Given this list of marker genes TUBA3E (NCBI Gene Id 150521), H2AZ1, SLC25A11 (solute carrier family 25 member 11), DDB2, CCNT2, STAG1, PCSK1, DLL4, PDGFRA, EGLN2, NIPBL, FHIP1B, MARCKSL1, DPYSL2, RIBC1, RAB11B, LUC7L2, STT3B, ARF3, ZIM2, RAD51, MAT2A, AUTS2, OSBPL7, H2AC12, CDKN1A, NUTF2, ATE1, DCK, LIG1, FMO4, SALL1, ANKHD1, JADE2, NRIP3, CTCF, MCM4, FBXL20, CTDSPL2, ATP6V1D, DMD, ASXL2, DCTPP1, ODAD3, YTHDC1 (YTH N6-methyladenosine RNA binding protein C1), SRSF1, REPS2, RET, SUGP1, ID3, DNAJC9, ZNF687, TCP1, PCYT2, NSD3, CSRNP1, CPSF7, TIPIN, PRKCSH, MRPL18, PLAGL1, AGFG2, RMI2, ING3, PTMA (prothymosin alpha), TMEM131L, DNAJC11, TOPBP1, CDC25A, DNMT1, TRIR, PAN2, MXD3, PDS5B, SMC1A, E2F7, MCMBP, CBX5, USP49, GPAT2, NR3C2, PUF60, ZBTB8OS, H2BC10, HNRNPD, FANCG, TMEM187, SEMA5A, POLA1, PLD5, SLC16A2, PPM1D, UXT, RBBP4, PPRC1, PRRT2, RHD (Rh blood group D antigen), KCNA6, DMC1 (DNA meiotic recombinase 1), JPH1, ORC1, SEZ6 (NCBI Gene Id 94007), RPL28, AP4M1, DIO3, HMGN2, NR6A1, E2F3, CDC45, LGALS1, DCLRE1A, POLA2, GRIA4, RNF121, PPP1R9B, TIAM1, ANP32A (acidic nuclear phosphoprotein 32 family member A), EIF4G2, CDCA7, RNF167, TRMT2A, ZSWIM9, LRRC56, PDS5A, DLST, YPEL5, ZIC3, ARHGAP6, ZDHHC17, EIF5A, KLHDC3 (NCBI Gene Id 116138), SRSF2, MCM2, ATAD2, ZNF565, EZH2, BTBD10 (BTB domain containing 10), NUP153 (NCBI Gene Id 9972), ZGRF1, GAPDH, PODN, EIF2S1, SERBP1, NHLRC2, TLE3, H1-3, SASS6, SLBP, NRGN, GLRA3, ZNF367, ZMYM2, KNTC1, PKMYT1, SIK2 (salt inducible kinase 2), PEG3, RSRC2, CTDSP1, FBXO5, FAM219A, RCOR2, KCTD15, DAXX, PPM1J, ARHGAP36, KLF5, CNBP, NR4A2, E2F1, NECTIN1, RANBP1, BRMS1L, MECOM, JADE1, EPHB1, RPS20, FAM120C, SUV39H1 (SUV39H1 histone lysine methyltransferase), STAG2, GABPB2, ARHGEF17, CASP8AP2, UFD1 (NCBI Gene Id 7353), MAZ, OVOL2, TOP1, KMT5A, KCND2, IER5L, ADAMTS2, ZNF362, EVA1B, PRPS1, NABP2, PRKDC, ARID4A, BMP7, PLK4, SMG1, TEX9, MELK, MCM7, FUS, MCM3, IPO7, SMC3, TREX2, MYC, MCM6, FKBP5, HNRNPA1, CENPB, PIM1, HNRNPA0, PRMT3, PAQR4, PCLAF, SMC2, CAND1, CACNA1G, VAMP3, PRIM1, ANKHD1-EIF4EBP3, SMAD6, RPA2, POLD1, SLITRK3, TBX3, TRMT13, INTS7, ANP32E, GMNN, STMN1, RBL1, MTF2, AK2, PCSK4, CDC6, NASP, RBFOX1, DDX17, E2F8, PRPF38A, UNG, RFC1, RHCE, RPS6KA5, SDHAF2, ZCCHC8, here is a description of the gene set: species: Homo sapiens Genes having at least one occurrence of the motif TTTSGCGCGMNR in the regions spanning 4 kb centered on their transcription starting sites. This matches the transcription factor binding site V$E2F_03 (v7.4 TRANSFAC). Human Gene Set: E2F_03